Given this list of marker genes PRKCE, PFN1, TMSB4Y (thymosin beta 4 Y-linked), MTSS2, COBLL1, TWF2, COBL, MTSS1, MYL2 (myosin light chain 2), ABL2, PFN2, TMSB10, MRTFA, NOS3, LMOD3, ABITRAM, ABL1, MYL4, TMSB4X, LMOD2, PKNOX2, TMSB15A, TMSB15C, TMSB15B (NCBI Gene Id 286527), PFN4 (NCBI Gene Id 375189), CORO1A, LIMA1 (NCBI Gene Id 51474), TWF1, MYL3, here is a description of the gene set: Human Gene Set: GOMF_ACTIN_MONOMER_BINDING studied in species Homo sapiens Binding to monomeric actin, also known as G-actin.